The following is a description of a gene set: Mouse Gene Set: CUI_MIGDC_IL15_RESPONSE_UP species: Mus musculus from publication Cui A, Huang T, Li S, Ma A, Pérez JL, Sander C, Keskin DB, Wu CJ, Fraenkel E, Hacohen N (PMID 38057668) Cytokines mediate cell-cell communication in the immune system and represent important therapeutic targets. A myriad of studies have highlighted their central role in immune function, yet we lack a global view of the cellular responses of each immune cell type to each cytokine. To address this gap, the authors created the Immune Dictionary, a compendium of single-cell transcriptomic profiles of more than 17 immune cell types in response to each of 86 cytokines (>1,400 cytokine-cell type combinations) in mouse lymph nodes in vivo. A cytokine-centric view of the dictionary revealed that most cytokines induce highly cell-type-specific responses. For example, the inflammatory cytokine interleukin-1β induces distinct gene programmes in almost every cell type. A cell-type-centric view of the dictionary identified more than 66 cytokine-driven cellular polarization states across immune cell types, including previously uncharacterized states such as an interleukin-18-induced polyfunctional natural killer cell state. Genes positively differentially expressed in cell type: MigDC (migratory dendritic cell) upon treatment with cytokine: IL-15 in mouse lymph nodes in vivo., and this is the list of marker genes: Ppa1, Irgm2, Plac8, Iigp1, Cxcl10, Rnf213, Ifi47 (NCBI Gene Id 15953), Cxcl9, Irf9, Parp9, Tap1, Irf8, Slfn5, Stat1, Zbp1, Samhd1, Ptpn1, Isg15, Irf1, Igtp, Gbp2, Trim30a, Calhm6, Ccnd2, Gbp5, Stat2, Serpina3g, Slfn2, Bcl2l11, Glipr2, Irgm1, Ifi209, Eif5a, Tle3 (NCBI Gene Id 70332), Tap2